Given this list of marker genes IRF1, CHUK, MIR29B1, TNFRSF10B, CASP9, XIAP, JUN, CASP10, PRF1, IGF1R, IRF6, BNIP3L, PIK3R1 (phosphoinositide-3-kinase regulatory subunit 1), CASP6, BAX (NCBI Gene Id 581), TNFRSF1A, BOK, SCAF11, HELLS (helicase, lymphoid specific), TRADD, MIR29A, CYCS, IGF2, TP73 (tumor protein p73), TNF, RELA, NFKBIE, BCL2, IKBKG, BAD, AKT1, MAP2K4, NFKBIA, ADAMTSL4-AS1, RIPK1, CASP3, TNFRSF25, TRAF3, MYC, CRADD, TP63, TRAF2, MAPK10, BCL2L2, MCL1, BIRC3, FAS, CASP7, IRF4, BID (NCBI Gene Id 637), HRK, IRF7, TNFRSF1B, NFKBIB, FADD, NFKB1, APAF1, IRF3, CDKN2A, CFLAR, BBC3, PMAIP1, MAP3K1, TNFRSF21, CASP8, CASP4, DFFB, CASP2, IRF2, DFFA, TP53, BCL2L1, BCL2L11 (NCBI Gene Id 150819), BAK1, FASLG, TRAF1, DIABLO, IRF5, BIRC5, GZMB, LTA, CASP1, BIRC2, IGF1, MDM2, TNFSF10, IKBKB, MIR29B2, here is a description of the gene set: studied in species Homo sapiens Human Gene Set: WP_APOPTOSIS Apoptosis